The following is a description of a gene set: studied in species Homo sapiens Human Gene Set: DESCARTES_FETAL_HEART_CLC_IL5RA_POSITIVE_CELLS The gene expression program underlying the specification of human cell types is of fundamental interest. The study authors generated human cell atlases of gene expression and chromatin accessibility in fetal tissues. For gene expression, the study authors applied three-level combinatorial indexing to >110 samples representing 15 organs, ultimately profiling ~4 million single cells. The study authors leveraged the literature and other atlases to identify and annotate hundreds of cell types and subtypes, both within and across tissues. Our analyses focused on organ-specific specializations of broadly distributed cell types (such as blood, endothelial, and epithelial), sites of fetal erythropoiesis (which notably included the adrenal gland), and integration with mouse developmental atlases (such as conserved specification of blood cells). These data represent a rich resource for the exploration of in vivo human gene expression in diverse tissues and cell types. from publication Cao J, O'Day DR, Pliner HA, Kingsley PD, Deng M, Daza RM, Zager MA, Aldinger KA, Blecher-Gonen R, Zhang F, Spielmann M, Palis J, Doherty D, Steemers FJ, Glass IA, Trapnell C, Shendure J (PMID 33184181) Marker genes curated from the annotated cluster as represented in the Descartes Human Gene Expression During Development database., and this is the list of marker genes: DAND5, LINC01629, PITRM1-AS1, MAN1A2P1, S100A1, RGS2, ZC2HC1C, CLC, TNMD, FAM209A, SLC6A7, LINC01681, C9, MS4A3, GLIS1, CERKL, DUOXA2, LRRIQ3, DBP, CTDSPL2-DT, PRG2, PDE6G, IL5RA, MINAR2